The following is a description of a gene set: The gene expression program underlying the specification of human cell types is of fundamental interest. The study authors generated human cell atlases of gene expression and chromatin accessibility in fetal tissues. For gene expression, the study authors applied three-level combinatorial indexing to >110 samples representing 15 organs, ultimately profiling ~4 million single cells. The study authors leveraged the literature and other atlases to identify and annotate hundreds of cell types and subtypes, both within and across tissues. Our analyses focused on organ-specific specializations of broadly distributed cell types (such as blood, endothelial, and epithelial), sites of fetal erythropoiesis (which notably included the adrenal gland), and integration with mouse developmental atlases (such as conserved specification of blood cells). These data represent a rich resource for the exploration of in vivo human gene expression in diverse tissues and cell types. studied in species Homo sapiens Human Gene Set: DESCARTES_FETAL_KIDNEY_MESANGIAL_CELLS Marker genes curated from the annotated cluster as represented in the Descartes Human Gene Expression During Development database. from publication Cao J, O'Day DR, Pliner HA, Kingsley PD, Deng M, Daza RM, Zager MA, Aldinger KA, Blecher-Gonen R, Zhang F, Spielmann M, Palis J, Doherty D, Steemers FJ, Glass IA, Trapnell C, Shendure J (PMID 33184181), and this is the list of marker genes: INSYN2A, RERG, MYOCD, LINC02820, SYNPO2, AGTR2, PHACTR3, PITX3, ATRNL1, COL25A1, ELOVL3, FGF19 (fibroblast growth factor 19), LINC01914, PITPNM3, LINC02720, ENSG00000205414, METTL24, SLC6A1, LINC02319, TCF21, TYRP1, CGB7, REN, SHC3, TMEFF2, PALLD, FOXS1, RMDN2-AS1, CPA6 (NCBI Gene Id 57094), CCBE1, TNC, COL8A1, LRRIQ1, LAMC3, GOT1L1, LINC02737, AGTR1, LAMA2 (NCBI Gene Id 3908), TBX22 (T-box transcription factor 22), NKD1, RARRES1, GNG8, RNU6-371P, NKD2, ALX1 (ALX homeobox 1), SLC7A14, ENPP1, APCDD1, GRID2, CCN4, IGLON5, SEZ6L2 (NCBI Gene Id 26470), KLHL13 (kelch like family member 13), PGM5P4, NKAIN2, LINC00924, NDP, BDNF